The following is a description of a gene set: part of: Intrinsic Pathway for Apoptosis Reactome Pathway: BH3-only proteins associate with and inactivate anti-apoptotic BCL-2 members species: Mus musculus This event has been computationally inferred from an event that has been demonstrated in another species.<p>The inference is based on the homology mapping from PANTHER. Briefly, reactions for which all involved PhysicalEntities (in input, output and catalyst) have a mapped orthologue/paralogue (for complexes at least 75% of components must have a mapping) are inferred to the other species. electronically inferred by orthology from the curated human pathway, and this is the list of marker genes: Pmaip1, Bcl2l1, Bad